Given this list of marker genes CMTM2, PBLD, MIR22HG, APOBEC4, LEMD1-AS1, PERP, KIZ, OCLN, DUSP22, DDIT3, ZNF700, NPL, SLC16A6, IL1RAPL1, OR5K1, TOLLIP, DDX17, TNFRSF1A, TULP4, DCAF1, RAPH1, TERF2IP, BTG3, CCDC90B, OSBPL2, NCOA2, DNAJC1, TRPV1, TRPC4, PSME4, FBXO28, MS4A8, CREB3L2 (cAMP responsive element binding protein 3 like 2), NCK1, SHE (Src homology 2 domain containing E), PRRG2, UBA6, MIA2, SLC35F5, GNA13, COX7B2, ZBTB16, CUL4A, MAFF, ZZEF1, RAB21, SPAG9, H4C8, LASP1, MEPE, FAM135A, FBXW11, S100PBP, PHB1P19, PITRM1-AS1, SLC6A12, PIAS4, PWWP2A (NCBI Gene Id 114825), PLCB4, ERMN, ARHGEF9, GPATCH8, MTMR11, FDPSP2, ATG14, GDF2, RER1, SUGT1P1 (SUGT1 pseudogene 1), H1-2, SLC22A4, GMNN, SLC7A11, ZNF143-AS1 (ZNF143 antisense RNA 1), DNAJC6, C3AR1, LINC01148, TEDDM1, GOLGA4, CXCR4, KNL1, TCEANC, DNAJC27, GADD45A, SMYD3, SLC35B1, KANSL3, LOXL1-AS1, BCL6, GOLGA3 (golgin A3), AP4B1, CCR5, GON4L, GPR37, POLR1H, CHD9, ATP1A2, ATG2B, WIPI1, SRRM2-AS1, MTMR9, BEND6 (BEN domain containing 6), HPGD, IER5, CD3D, DHX36, ZBTB43, GAS2, GLI3, RALGAPA2, LINC00662, SENP2, LYSMD3, GGTA1, MAPK13, ZFYVE16, BUB1, VPS54 (VPS54 subunit of GARP complex), RGS1, ANKRD30B, GOLIM4, UNC50, USP7, WDR91, NRF1, GMFG, DCBLD1, ZNF671, ZNF233, ICA1L, RSC1A1, ANKS4B, WIPF1, ABHD5, RASGRP1, SF3B5, HMGB3P1 (high mobility group box 3 pseudogene 1), DHTKD1, ESCO1, FOSL2, STAG3L4, DCUN1D2, ETAA1, C8orf76, GAPVD1, LRRC37BP1, C7orf50, BPIFB4, TBC1D12, GPNMB (glycoprotein nmb), ZDHHC8BP, CBX5, USP38, MON2, RASL12, DENND4A, BTBD10, ETFDH, MLYCD, IRAK2, MOGS, SLC3A1, ELP6, NALF2, ZNF148, SPG7, TRIP4, ASB10, LELP1, AQP4-AS1, MGAT5, FIS1, TTLL1, FAM13A-AS1 (NCBI Gene Id 285512), CCDC91, CACUL1, ARL1, RXRA, BMP2K (NCBI Gene Id 55589), ALCAM, TCP10L, RELN, XIAP, STK10, BBX, UBXN8 (UBX domain protein 8), E2F6, MAP7D3, FECH, here is a description of the gene set: species: Homo sapiens We used microarrays to detail the global programme of gene expression by circulating TCRVgamma9+ gamma delta T cells isolated from healthy individuals,tested either as resting cells or cells activated by phosphoantigen BrHPP and IL-2at an early(+6hrs) and a late (+7days) timepoint. We find that with more “NK cell” genes than alphabeta T cells and more “T cell” genes than NK cells, the circulating TCRVgamma9+ gamma delta T cells cells have a hybrid transcriptome. The gene signature of the activated cells recapitulates their physiological functions: Th1 cytokine, chemokine and cytotoxic activities at first and mitotic activity at later time points. The gene expression pattern of activated normal gamma delta T cells is nevertheless clearly distinctive from that of NK/T and peripheral T cell lymphomas of the gamma delta subtype. Human Gene Set: GSE27291_0H_VS_7D_STIM_GAMMADELTA_TCELL_UP Genes up-regulated in gamma delta T cells activated by phophoantigen BrHPP and IL2: 0h versus 7 days. from publication Pont F, Familiades J, Déjean S, Fruchon S, Cendron D, Poupot M, Poupot R, L'faqihi-Olive F, Prade N, Ycart B, Fournié JJ (PMID 21968650)